Given this list of marker genes Ppp2r5d, Ppp2r1b, Mapk1, Dusp7, Dusp4, Ppp2ca, Dusp3, Dusp6, Ppp2r1a, Mapk7, Mapk3, Vrk3, Ppp2cb, here is a description of the gene set: ERKs are inactivated Mouse Gene Set: REACTOME_ERKS_ARE_INACTIVATED studied in species Mus musculus